The following is a description of a gene set: Genes up-regulated during in vitro maturation of CD14+ monocytes (day 0) into immature (day 7) and mature dendritic cells (day 14). Dendritic cells (DCs) are antigen-presenting cells that play a major role in initiating primary immune responses. We have utilized two independent approaches, DNA microarrays and proteomics, to analyze the expression profile of human CD14(+) blood monocytes and their derived DCs. Analysis of gene expression changes at the RNA level using oligonucleotide microarrays complementary to 6300 human genes showed that approximately 40% of the genes were expressed in DCs. A total of genes (4%) were found to be regulated during DC differentiation or maturation. Most of these genes were not previously associated with DCs and included genes encoding secreted proteins as well as genes involved in cell adhesion, signaling, and lipid metabolism. Protein analysis of the same cell populations was done using two-dimensional gel electrophoresis. A total of 900 distinct protein spots were included, and 4% of them exhibited quantitative changes during DC differentiation and maturation. Differentially expressed proteins were identified by mass spectrometry and found to represent proteins with Ca(2+) binding, fatty acid binding, or chaperone activities as well as proteins involved in cell motility. In addition, proteomic analysis provided an assessment of post-translational modifications. The chaperone protein, calreticulin, was found to undergo cleavage, yielding a novel form. The combined oligonucleotide microarray and proteomic approaches have uncovered novel genes associated with DC differentiation and maturation and has allowed analysis of post-translational modifications of specific proteins as part of these processes. Human Gene Set: LENAOUR_DENDRITIC_CELL_MATURATION_UP species: Homo sapiens from publication Le Naour F, Hohenkirk L, Grolleau A, Misek DE, Lescure P, Geiger JD, Hanash S, Beretta L (PMID 11279020), and this is the list of marker genes: IARS1, CYB5A, HLA-DPB1, CAT, MGLL, CCL17, HMGN3, SHB, MMP12, MMD, GDF15, CCL13, C1QB, TFRC, TRIB2, SPTAN1, OAT, DUSP1, QSOX1, PFKM, ST6GAL1, SULT1C2, HLA-DPA1, CCR7, DNASE1L3, DUSP5, CCNA1, HLA-DQA1, FCGR2A (NCBI Gene Id 90764), PPIC, CCNG2, ABCG1, CITED2, RNASE6, SPINT2, SNRPN, CCND2, TNFAIP6, CCL22, CD1A, SOX4, RRP1B, ITPKB, ACOT7, BIRC3, ACOT2, KCNAB2, LPL, NR4A3 (nuclear receptor subfamily 4 group A member 3), APOC1, PFKP, CCDC85B, INHBA, SCRN1, NCAPH, CR1, SCARB1, CTSC, RNASE1, SPP1, ARF4, FABP5, ATP1B1, SLC11A2, CD86, ALOX15, LGALS3BP, CDH1, PTPRO (protein tyrosine phosphatase receptor type O), RARRES1, CSF1, CD59, SERPINB6, FABP4, TGFA, PPARG, ENPP2, MRC1, TGM2, FCER2, PDLIM4, ECM1, ACAA2, CD83 (NCBI Gene Id 9308), RAP1GAP, GAS6, CD1B, GATM, SEMA3C, CD74, CBS, ITGB5, PKD2, APOE (NCBI Gene Id 99), STAC, IRF4, CEBPA (NCBI Gene Id 1050), HLA-DQB1, DPP4, PEBP1, CCNH (NCBI Gene Id 902), PCBD1, BLTP2, PRKACB, LIPA, MAOA, FABP3, IDO1 (NCBI Gene Id 3620), TLE5, NR1H3, SLA, A2M, CD1C, HSD11B1, CRABP2, F13A1